The following is a description of a gene set: We developed a versatile, high-throughput genetic screening strategy by coupling gene mutagenesis and expression profiling technologies. Using a retroviral gene-trap vector optimized for efficient mutagenesis and cloning, we randomly disrupted genes in mouse embryonic stem (ES) cells and amplified them to construct a cDNA microarray. With this gene-trap array, we show that transcriptional target genes of platelet-derived growth factor (PDGF) can be efficiently and reliably identified in physiologically relevant cells and are immediately accessible to genetic studies to determine their in vivo roles and relative contributions to PDGF-regulated developmental processes. The same platform can be used to search for genes of specific biological relevance in a broad array of experimental settings, providing a fast track from gene identification to functional validation. species: Mus musculus Human Gene Set: CHEN_PDGF_TARGETS Up-regulated PDGF targets identified by a gene-trap screen. from publication Chen WV, Delrow J, Corrin PD, Frazier JP, Soriano P (PMID 14981515), and this is the list of marker genes: SCHIP1, KLF2, ZFAND5, KLF9, LMNA, MCL1, JADE1, SGPL1, GPD2, GOT1, UCK2, ARID5B, EPHA2, TIPARP, SLC2A2 (solute carrier family 2 member 2), PLEKHA1, MYO1E, CSRNP1